Given this list of marker genes Rela (NCBI Gene Id 19697), Psenen, Nfkb1, Psen1, Ngfr, here is a description of the gene set: species: Mus musculus Reactome Pathway: Regulated proteolysis of p75NTR part of: p75 NTR receptor-mediated signalling This event has been computationally inferred from an event that has been demonstrated in another species.<p>The inference is based on the homology mapping from PANTHER. Briefly, reactions for which all involved PhysicalEntities (in input, output and catalyst) have a mapped orthologue/paralogue (for complexes at least 75% of components must have a mapping) are inferred to the other species. electronically inferred by orthology from the curated human pathway